Given this list of marker genes RAB31, TXNL4B, PRSS8, MEF2A, KRTAP4-8, SLC66A2, GIPC3, POU4F2, CCDC88A, UBE2D2, SWI5, GNG13, CUL5 (cullin 5), RELB, RGMB, KRTAP4-9, RNF11, RSKR, ANKRD13C-DT, KRTAP4-11, DCAF17, PTGFRN, NEK11, FAM120AOS, FAT3, ONECUT2, ARMC10, NGEF, TCF19, INTS9, ZIC4, SKIDA1, PTPRM, MYH10, FBXL16, ZNF48, RRH, here is a description of the gene set: from publication Chen Y, Wang X (PMID 31504780) Human Gene Set: MIR10400_3P_MIR4674 species: Homo sapiens Genes predicted to be targets of miRBase v22 microRNA hsa-miR-10400-3p, hsa-miR-4674 in miRDB v6.0 with MirTarget v4 prediction scores > 80 (high confidence targets).